The following is a description of a gene set: Mouse Gene Set: GOMF_CALCIUM_ION_BINDING Binding to a calcium ion (Ca2+). species: Mus musculus, and this is the list of marker genes: Casq1, Smoc1, Mctp2, Necab2, Fat3, Adgrv1, S100g, Pla2g1b, Thbs4 (thrombospondin 4), Ppp2r3d, Pla2g4f, Itsn2, Fkbp9, Actn4, Pla2g12b, Clstn1, Aif1, Plch1, Prrg3, Lpcat2, Cdh6, Nkd2, Ehd4, Cacna1b, S100a10, Proz, Anxa5, Pcdhb18, Atp2c1, Anxa7, Egfl8, Pcdha10, Celsr2, Padi3, Anxa3 (annexin A3), Pcdhb8, Fam20c, Cib2, Pcdh20, Ldlr, Pcdh18, Ccbe1, Caps2, Calr4, Stab2, Aoc1l2, Kcnip2 (Kv channel-interacting protein 2), Ppp3r1, Lcp1, Amy2a5, Otof, Cabp7, Prrg4, Tll2, Myl2, Svep1, Capn1, Ppp2r3a, Cdh15, Celsr3, Efhc1, Nol3, Amy1, Cdh22, Tesc, Anxa8, Acer3, Spock2, Sulf2, S100a1, Tgm2, S100a7a, Edem2 (NCBI Gene Id 98934), Cdh20, Capn3, Cib1, Itpr3, Nucb1, Gjb2, Slit1, Cdh3, Clstn2, Pitpnm2, Bglap, Sptan1, Pls1, Stim2, Capsl, Lpcat2b, Vldlr, Matn4, Dchs1, Capn2, Clec4a3, Clec4a1, Vil1, S100a7l2, Lrp1, Prrg2, Egfl7, Efemp2, Anxa2, Gsn, Ids, Cabp5, Chp2, Enpp3, Itsn1 (NCBI Gene Id 16443), C2cd5, Ppef1, Vcan, Hpcal1, Tnnc2, Pcdh19, Cdh13 (cadherin 13), Calml4, Cacna1e, S100b, Capns2, Pitpnm1, Asah2, Cdh7, Edem1, Selenon (selenoprotein N), Cabp2, Nell1, Aoc1l1, Capn12, Calml3, Efhb, Creld2, Egf, Bcl2l10, Efhd1, Duox2, Prss2, H1f4, Syt10, Reps1, Nucb2, Cdhr1, Lrp2, Hrnr, Pcdha9, Efcc1, Itpr1, Cblc, Pla2g4b, Mbl1 (mannose-binding lectin (protein A) 1), Pls3, Dsg2, Matn1, Acan, Npnt, Cblb, Bglap2, Actn3, Anxa11, Pla2g2a, Pkd1l3, Tbc1d8b, Slc25a25, Clxn, Lrp1b, Calr3, Slc25a13, Calr, Myl1, Adgre4, Fkbp7, Unc13a, Fkbp14, Ehd1, Cemip2 (NCBI Gene Id 83921), Cdh5, Edem3, Tpo, Notch2, Celsr1, Nin, Thbs3, Pla2g4e, Oc90, Pcp4, Sntn, Syt7, Dll1, S100a3, Anxa10, Pla2g10, Vsnl1, Sele, Fbln5, Pnliprp1, Cracr2a, Clec3b, Plcb2, Mcfd2, Anxa4, S100a11, Cps1, Padi2, Ltbp2, Spata21, Sned1, Mbl2, Rhot2, Plch2, Calm1, Pkdrej, Pnliprp2, Pcdh15, Hmcn1, Casr, S100a8, Naaladl1, Anxa13, Efcab5, Crtac1, Unc13c (NCBI Gene Id 70254), F9, Egfem1, Itgb1, Cd93, Dhh, Tgm3, Myl7, Cdh4, Cdh26, Rasgrp1, Mmp12, Itpr2, Spock3, Calm2, Pam, Cdhr2, Enpp2, Egfl6, Plscr2, Macf1, Srr, Aoc1l3, Capns1, Caln1, Syt2, Syt11, Eps15, Fstl5, 1700109H08Rik, Usp32, Gm5849, Aoc1, Trpm5, S100z, Gca, Unc13b, Padi6, Calm4, Rasgrp2, Nid2, Clec4a2 (C-type lectin domain family 4, member a2), Fbln7, Pitpnm3, Galnt3, Smoc2, Syt1 (NCBI Gene Id 20979), Pdcd6, Adgre1, Proc, Enpp1, Runx1, S100a4, Loxl2, Bglap3, Fstl4, Jag1, Atp2a1, Pcdh8, Dsc2, Esyt1 (extended synaptotagmin-like protein 1), Gch1, Cdh2, Hpgds, Colec11, Efcab7, Tnfaip6, Cdh10, Ryr3, Kcnip3, Dsc3, Melk, Rhot1, Efhd2, Pla2g5, Pcdha7, Padi4, Lrp8, Agrn (agrin), Padi1, Pros1, Myl6b, Fat4, Nkd1, Man1a2, Itih4, Myo5a, Cab39, Actn2, Fbn1, Try4, Tnnc1, Adgrl3 (NCBI Gene Id 74495), Dlk2, Thbs2, Fscb, F12, Reps2, Trpm4, Vwa2, Tpd52, Pla2g12a, Dner, Pla2g4c, Cgref1, Chordc1, Tll1, Adam8, Ncald, Astn2, Myl4, Rcn1, Slc25a24, Stab1, Tbc1d9b, Guca1b (NCBI Gene Id 224830), Pla2g4d, Slc25a12, Nid1, Fstl1, Cbl, Prss1l, Hmcn2, Cetn4, Pvalb, Clstn3, Scube1, Dag1, Edil3, Gas6, Thbd, Efcab3, Cib3, Crp, Vwce, Dsg1a, Sulf1, Crnn, Shh, Lrp4, Cdh9, Man1b1, Mctp1, Dll4, Otol1, Aoc3, S100a14, Itln1, Ehd3, Doc2b, Prss3l, Ltbp3, F10, Myl10, Notch4, Plcg1, Canx, Eef2k, Dsg3, Tescl, Capn13, Braf, Trpm2, Pkd2l2 (polycystic kidney disease 2-like 2), Jag2 (jagged 2), Habp2, Cabcoco1, Amy2a2, Kcnip1 (Kv channel-interacting protein 1), Selp, Plcd4, Dsg1c, Rph3a, S100a6, Esyt2, Cabp1, Ppp3r2, Cdh12, Cdh16, Rab11fip3, Cdh24, Clgn, Esyt3, Man1c1, Lalba, Lpl (NCBI Gene Id 16956), Anxa9, Tchhl1, Ocm, Syt5, Rcn3, Calm3, Sri, Amy2a3, Pcdha4, Mmrn1, Cetn1, Myl9, Efcab10, Myl3, Aoah (acyloxyacyl hydrolase), Dlk1, Syt4, Itgb1bp2, Scube3, Rcn2, Slc25a23, Cib4, Efcab2 (EF-hand calcium binding domain 2), Dgkg (NCBI Gene Id 73000), Micu3, Efcab9, Hpca, Mmp8, Cadps, Pclo, P4htm, Amelx (amelogenin, X-linked), S100a5, Pla2g2c, Necab3, Clec4a4, Myl12b, Crb1, Atp5f1b, Ihh, Pdp1 (pyruvate dehydrogenase phosphatase catalytic subunit 1), Dsg4, Pcdhb6, Aspn, Cdh8, Baiap3, Ttyh3, Umodl1, Pkd2, Cabp4, Micu1, Apcs (NCBI Gene Id 20219), Slc8a1, Capn11, Cd248, Pla2g2e, Rcvrn, Matn3, Heg1, Matn2, S100a9, C1ra, Dysf, Megf6, S100a2, Notch3, Asph, Plcb1, Scube2, Casq2, Aif1l, Tbc1d9, Mylpf, Adgrl4, Comp, Arsa, C1s2, Dst, Dgkb, Snca, Bmp1, Cabs1, Ttn, Calu, Tpt1, Ppef2, Try10, Creld1 (cysteine-rich with EGF-like domains 1), Pon1, Eps15l1, Amy2a1, Sparcl1, Plscr1 (phospholipid scramblase 1), Cetn2, Mgmt, Cdh17, Glce, Efcab11, Bcan, Ryr2, Dchs2, Calm5, F7, C1s1, Stim1 (NCBI Gene Id 20866), Atp2b2, Masp1, Gnptab (NCBI Gene Id 432486), Dll3, Grm7, Sdf4, Camkk2, Hrc, Try5, Mmp13, Ttyh2, Crb2, Slit2, Amy2a4, Cdhr5, Rab11fip4, Hspg2, Notch1, Sparc, Ncan, Calb2, Spta1, Prss1, Alox8, Ltbp4, Zzef1, Spock1, Sgca, Masp2, Rhbdl3, Ccdc47, Ncs1, Hpcal4, F2, Sell, Fbln2, Tkt, Cracr2b, Anxa1, Prss3, Umod, Egflam, Pla2g2d, Nrxn1, Sncb, Adgre5, Itga5, Pcdh12, Efemp1, Pkd2l1, Lpcat1, Tubb4a, Ret (NCBI Gene Id 19713), Slit3, Clec4e, Pla2g2f, Gpd2, C1rb, Plcd1, Plscr3, Anxa6, Cdk5r1, Pla2g4a, Flg2, Plcb3, S100a16, Pkd1l2, Epdr1, Thbs1, Dsg1b, S100a13, Rptn, Cdhr3 (NCBI Gene Id 68764), Prkcsh, Cabyr, Fkbp10 (NCBI Gene Id 14230), Calb1, Oit3, Efcab6, Cd320 (NCBI Gene Id 54219), Ppp3cb, Micu2, Actn1, Pef1, Cdh11 (cadherin 11), Man1a, Cdh1, Fat2, Capn9, Fbln1, Plcz1, Atp2a2, Cant1, Dgka, Rgn, Alpl, Ryr1, Cdh23, Prf1, Cd69, Pcdhb14, Grin1 (NCBI Gene Id 14810), Fbn2, Scgn, Dsc1, Cetn3, Ltbp1, Ehd2, Necab1, Mgp, Clec4n, Efcab8, Myl6, Ttyh1, Ncl, Cpne1, Cubn, Pcdhga4, Nell2, Kcnip4, Iqgap1, Ninl, Megf8, Chp1, Pamr1, Guca1a